The following is a description of a gene set: Verteporfin is a porphyrinic photosensitizer clinically used for the photodynamic treatment of age-related macular degeneration. The authors previously tested the efficacy of Verteporfin in endometrial cancer cells and observed cytotoxic and anti-proliferative effects. from publication Bang LG, Dasari VR, Kim D, Gogoi RP (PMID 30846786) Tha authors analyzed RNA sequencing data to investigate the comprehensive transcriptomic landscape of Verteporfin treated Type 1 endometrial cancer cell lines, including HEC-1-A and HEC-1-B. species: Homo sapiens Mouse Gene Set: BANG_VERTEPORFIN_ENDOMETRIAL_CANCER_CELLS_UP, and this is the list of marker genes: Dsg2, Tfpi2, Egr1, Ankrd1, Adam9, App, Col4a2, Nup210, Itgav, Ganab, Itgb4, Gpc4, Atp6ap2, Os9, Col12a1, Sema3c, Gba1, Thbs1, Vcan, Ccn1